The following is a description of a gene set: studied in species Homo sapiens Pathway Definition from KEGG: Ser/Thr+Man-P-Dol -- POMT1/2 >> POMGNT2 >> B3GALNT2 >> POMK -> G13092 Human Gene Set: KEGG_MEDICUS_REFERENCE_MANNOSE_TYPE_O_GLYCAN_BIOSYNTHESIS_POMT_TO_POMK Mannose type O-glycan biosynthesis, POMT to POMK. Pathway ID: N00627. Pathway type: Reference. Pathway class: nt06013 O-Glycan biosynthesis., and this is the list of marker genes: B3GALNT2, POMT1, POMK, POMGNT2, POMT2